Given this list of marker genes Nradd, Plaat1, Tubb5, Fam3b, Alox5, App, Ptges, Cacybp, Ccar1, Igf2r, Cd2ap, Sorl1, Bche, Tamalin, here is a description of the gene set: species: Mus musculus The region between the two lipid bilayers of the nuclear envelope; 20-40 nm wide. Mouse Gene Set: GOCC_NUCLEAR_ENVELOPE_LUMEN